Given this list of marker genes TBX6, BCAS3, TDG, LEFTY2, ADAM11, TFAP4, FASTK, SAMM50, RUNX3, PCDH11X (NCBI Gene Id 93452, protocadherin 11 X-linked), MRPL54, LUC7L3, WBP2, ATL2, ZDHHC15, SNAPC3, CLEC18C, POLR1B, GTPBP8, UBE2V1, CCDC120, HOXD8 (NCBI Gene Id 56182), COQ10A, IL17RC, CACFD1 (NCBI Gene Id 11094), ZW10, TGFB3, ST3GAL1, NSD3, GSC, IRF2BP1, CCT8, ZC4H2, RANBP3, IER3, PRKN, PHLPP1, PABPC1, SOWAHC, HACE1, FBXL19-AS1, APBA3, SNX27, SLC9A1, PTPN23, ZNF485, MIB2, PCDH11Y, CERT1, GRWD1, WNK1, GTF3C2, BACH2, CDK9, GSPT1, POLK, SKP2, ERO1B, ORMDL3, APH1A, SEPTIN10, KCNJ13, HS6ST2, ATL3, BTBD1, FLOT1, TCEAL1, NTN3, RPS6KB2 (ribosomal protein S6 kinase B2), MITF, PPP2R3A, RDH12, PACRG, OSM, here is a description of the gene set: Genes having at least one occurrence of the highly conserved motif M114 YTCCCRNNAGGY in the regions spanning 4 kb centered on their transcription starting sites. The motif does not match any known transcription factor binding site. studied in species Homo sapiens from publication Xie X, Lu J, Kulbokas EJ, Golub TR, Mootha V, Lindblad-Toh K, Lander ES, Kellis M (PMID 15735639) Human Gene Set: YTCCCRNNAGGY_UNKNOWN Comprehensive identification of all functional elements encoded in the human genome is a fundamental need in biomedical research. Here, we present a comparative analysis of the human, mouse, rat and dog genomes to create a systematic catalogue of common regulatory motifs in promoters and 3' untranslated regions (3' UTRs). The promoter analysis yields 174 candidate motifs, including most previously known transcription-factor binding sites and 105 new motifs. The 3'-UTR analysis yields 106 motifs likely to be involved in post-transcriptional regulation. Nearly one-half are associated with microRNAs (miRNAs), leading to the discovery of many new miRNA genes and their likely target genes. Our results suggest that previous estimates of the number of human miRNA genes were low, and that miRNAs regulate at least 20% of human genes. The overall results provide a systematic view of gene regulation in the human, which will be refined as additional mammalian genomes become available.